The following is a description of a gene set: Genes having at least one occurence of the motif TCCAGAG in their 3' untranslated region. The motif represents putative target (that is, seed match) of human mature miRNA hsa-miR-518c* (v7.1 miRBase). studied in species Homo sapiens Human Gene Set: TCCAGAG_MIR518C, and this is the list of marker genes: ZMYND11 (NCBI Gene Id 10771), ARID5B, RHOT1, PARP6, RANBP10, GCLC, SPATA45, HNRNPAB, CHKB, CCDC144BP, ELAVL1, SGMS1, GPRC5B, STC1, PHF21A, PCDHGA9, RALA, ZDHHC9, PCDHGB4, SMCR8, PCDHGA8, DDT, PSME3, PCDHGA1, WDR1, PCDHGC3, GRK5, PCDHGB5, GDAP2 (ganglioside induced differentiation associated protein 2), SLC38A2, RPGRIP1L, ACACA, NCF4, PCDHGA12, GRB2, TMEM184B, ZNF652, LSM12, NRXN2, TCF12, CAMK2G, ANKRD26P1, RBBP5, RAB15, ING3, RND1 (Rho family GTPase 1), SPRY2, AGO1, PREB, PCDH19, PCDHGB6, MEOX2, RALGAPB, ST8SIA2, AIRE, MLX, PCDHGA3, MSTN, SMPD3, KDM2A, LINC00336, SALL2, C6orf62, IL18BP, PCDHGB7, MOB3B, CUX2, PCDH9, ITGB3, MICAL2, PCDHGB2, MARF1, HMGN1, VAMP5, IQCB1, TAF4 (NCBI Gene Id 6874), ST3GAL4, PCDHGA11, PCDHGA10, ADGRL1, HOXA1, GAD1, PCDHGA4, ETV5, BACH2, PRX, CDC42, PCDHGA5, PPP1R12B, NALF2, CSNK1G1, PATZ1, PCDHGC4, ANK2, NR4A2, TNK2, LZTFL1, PCDHGB1 (NCBI Gene Id 56104), PUM1, ELOF1, TNKS2, SDK2, AXL, SMURF2, PCDHGB3, ZNF606, TWIST1, CHCHD3, CLUH, NCOR2, SGCD, NFIX, SLC30A4 (NCBI Gene Id 7782), MEIS2, SH2B3, DLL4, CSNK2A1, CBX7, RICTOR, NFAT5, MECP2, PCDHGA2, SYT7, DSEL, RBM47, SULF1, RHOQ, RBFOX1, ZFAND5, KDM5C, PCDHGA6, PCDHGA7, PYM1, GTDC1, MED12L, ATP2A2, DNMT3A, GGA3, SELENOI, MKLN1, GOLGA7, SEPTIN4, CD34, MAPK1, TCERG1, PRR3, PCDHGC5, COQ10B, RNF44